Given this list of marker genes ARG1, here is a description of the gene set: part of: Diseases of the urea cycle ARG1 is a cytosolic enzyme that is highly expressed in the liver and expressed at a lower level in the kidney. It catalyzes the final step of the urea cycle, the conversion of L-arginine to urea and L-ornithine (Di Costanzo et al, 2005). Arginase 1 deficiency, also known as argininemia (OMIM 207800) is an autosomal recessive inborn error of metabolism that is characterized by elevated arginine levels and leads to spastic paraparesis, neurological and developmental delays. Unlike other urea cycle defects, hyperammonemia is not a common manifestation of arginase 1 deficiency. Reactome Pathway: ARG1 variants cause hyperargininemia studied in species Homo sapiens